Given this list of marker genes Psen1, Ctsl, Nfe2l1, Piwil1, Mei1, Nfib, Haspin, Akt1, Xrcc5, Spo11, Ctnnb1, Nanos2, Sycp2l (NCBI Gene Id 637277), Cdk6, Nfia, Mlh1, Ube2b, Tgfb2, Ptgs2, Fancb, Psen2, Ppard, Nfatc1, Lin37, Gsdma3 (NCBI Gene Id 450219), Notch1, D1Pas1 (DNA segment, Chr 1, Pasteur Institute 1), Msx2, Piwil2, Fance, Dsg4, Mreg, Nfix, Wnt10b, Gpr149, Cdh3, Nkx2-1, Sycp2, Cdc20, Topaz1, Krtap21-1, Mir489, Fermt1, Gal, Terf1, Myo5a, Jmjd1c, Trex1 (NCBI Gene Id 22040), Trpv1, Dek, Ttk, Chek2, Paupar, Barx2, Wnt5a, here is a description of the gene set: Mouse Gene Set: GOBP_BIOLOGICAL_PHASE studied in species Mus musculus A distinct period or stage in a biological process or cycle.